Given this list of marker genes Il17ra, Il1rap, Tnfsf4, Nlrp3, Il18, Irf4, Prkcz, H2-T23, Il4, Gata3, Il33, Sphk2, Rara, Tlr4, Tslp, Il17rb, here is a description of the gene set: Any process that activates or increases the frequency, rate, or extent of interleukin-13 production. species: Mus musculus Mouse Gene Set: GOBP_POSITIVE_REGULATION_OF_INTERLEUKIN_13_PRODUCTION